Given this list of marker genes AASS, SLC25A13, SLC7A7, ASL, ASS1, here is a description of the gene set: An increased concentration of citrulline in the blood. Elevated plasma citrulline species: Homo sapiens Human Gene Set: HP_ELEVATED_PLASMA_CITRULLINE